Given this list of marker genes HSD17B10, POGLUT2, GTF3C3, PEX7 (NCBI Gene Id 5191), METTL5, CTC1, HERC4, PSMD14, INTS3, TLE4, DYNC2I1, CHMP5, MRPL37, DPP3, CYB5A, MKKS, TRIM14, PIGX, C1orf122, MZB1, ALDOC, TRIP4, PRKDC, TMEM256, FAM3A, CCNG1, MRPL35, CCNH, KYAT3, MCM5, FCGR2B (Fc gamma receptor IIb), ACOT7, SLC25A45, PTDSS2, TCF4, ACAD9, SLC48A1, CDK2AP1, CENPM, DYNLRB1, PSMB1, PRIM1, BCL2, PRPF6, CEP57L1, NDUFA2, POLE2, NAA38, BCAT1, PPIL3, PACRGL, TIMM22, PPP1CA, MRPS22, MRM2, MRPS18C, FAM174C, KIFBP, HSPA8, PRPF31, TNS3, SLC2A6, PITHD1, PARD6A, PUS10, MRPL52, MACROD1, SUCNR1, SPR, AHCY, FKBP3 (NCBI Gene Id 2287), CISD3, ARHGEF6, UFC1, NMT1, STRBP, DUSP19, DYNLL1, CHCHD6, MED22, PDCL3, PDGFA, CYB561D2, ATP5MC1, PRDX1, EEF1AKMT2, NICN1, VANGL2, TNFRSF18, APOOL, MRPL1, COQ3, MSL3, BPGM, TIMM21, DROSHA, TMEM126A, ECH1, AGTRAP, TONSL, MOCS2, FUNDC1, MRPL47, MED30, TMTC4, RPA1, DIPK1B, C22orf39, ARL6, EIPR1, MDH2, RGS14, ABHD12, MPHOSPH6, FAM98B, ZNF771, GSTM3 (NCBI Gene Id 2947), YIF1B, VDAC3, RBL1, NUBPL, TMEM164, PPP1R7, GDPD1, ID3, HIBADH, REX1BD (NCBI Gene Id 55049), SMPD1, AIFM1, GTF3C5, ZSWIM1, ROMO1, PYCARD, PSMA5, MRPS28, RAC1, ZNF217, BCL9L, PIAS3, MAOA, PSMA1, MVK, LARP6, ZNF560, ECI1, DLAT, TSPAN2, COX11, IAH1, NDUFV2, LRSAM1, PSMD13, NT5DC1, SEM1, CCS, INTS9, DTL, DCAF17, SLC39A4, LRWD1, FLAD1, SCNM1, GLMN, CCDC90B, PGK1, INTS8, PXMP4 (NCBI Gene Id 11264), WWP1, CDC123, CAT, FLOT2 (NCBI Gene Id 2319), AGBL5, ODF2L, MAN2C1, DERA, CAMLG, HELLS, SMIM19, UBA2, PTGR2, CDKAL1, TMEM134, MTA3, NCF4, SPATA7, TST, CCDC34, VWA8, BCKDHB, SPATA24, MRE11, OXSM, KLHL14, ZNG1B, ECHDC1, TBC1D10C, NAXE, IRF2, ELP4, here is a description of the gene set: Genes up-regulated in CD4 T cells: untreated versus IL1B and IL6. from publication Ghoreschi K, Laurence A, Yang XP, Tato CM, McGeachy MJ, Konkel JE, Ramos HL, Wei L, Davidson TS, Bouladoux N, Grainger JR, Chen Q, Kanno Y, Watford WT, Sun HW, Eberl G, Shevach EM, Belkaid Y, Cua DJ, Chen W, O'Shea JJ (PMID 20962846) CD4+ T cells that selectively produce interleukin (IL)-17, are critical for host defense and autoimmunity1-4. Crucial for T helper17 (Th17) cells in vivo5,6, IL-23 has been thought to be incapable of driving initial differentiation. Rather, IL-6 and transforming growth factor (TGF)-β1 have been argued to be the factors responsible for initiating specification7-10. Herein, we show that Th17 differentiation occurs in the absence of TGF-β signaling. Neither IL-6 nor IL-23 alone efficiently generated Th17 cells; however, these cytokines in combination with IL-1β effectively induced IL-17 production in naïve precursors, independently of TGF-β. Epigenetic modification of the Il17a/Il17f and Rorc promoters proceeded without TGF-β1, allowing the generation of cells that co-expressed Rorγt and T-bet. T-bet+Rorγt+ Th17 cells are generated in vivo during experimental allergic encephalomyelitis (EAE), and adoptively transferred Th17 cells generated with IL-23 in the absence of TGF-β1 were more pathogenic in this experimental disease. These data suggest a new model for Th17 differentiation. Consistent with genetic data linking the IL23R with autoimmunity, our findings re-emphasize the role of IL-23 and therefore have important implications for the development of new therapies. studied in species Homo sapiens Human Gene Set: GSE23505_UNTREATED_VS_4DAY_IL6_IL1_TREATED_CD4_TCELL_UP